Given this list of marker genes TCN2, SLC11A2, MMGT1, SLC41A2, CBLIF, TCN1, SLC39A8, SLC30A5, here is a description of the gene set: The directed movement of cobalt (Co2+) ions into, out of or within a cell, or between cells, by means of some agent such as a transporter or pore. studied in species Homo sapiens Human Gene Set: GOBP_COBALT_ION_TRANSPORT